Given this list of marker genes CRPPA, CTC1, MATR3, KCNJ13, NECAP1, PYCR2, MTHFR, ATP5F1A, DOLK, NIPA1, IKBKG, NOP56, ATP6V0A1, NAXD, ARSI, PTEN, HNRNPA2B1, LMNB1, ATP6AP2, CYP26C1, BBIP1, DLL4, CDON, MEOX1, AMFR, MAN2B1, PMS1, ERCC1, DOCK6, DPYD, NR2F1, MRPS34, BBS9, PRUNE1, TRAPPC4, TMEM222, FAR1, GSS, RNASEH2A, ZC4H2, TNR, DNAJC3, PDGFB, RLIM, NR4A2, TECPR2, FARS2, GTPBP2, GAS1, YRDC (NCBI Gene Id 79693), MOCS2, UBE4B (NCBI Gene Id 10277), PRPH, COL3A1, FUCA1, WWOX, UFC1, GALC, KCNA2, RPS6KA3, NDUFS1, HACE1, MYORG, DCX, MFSD2A, AARS1, ARL6IP1, SP110, EIF2AK1, GBA1, CWF19L1, KCNA1, SLC25A12, HPDL, RORA (RAR related orphan receptor A), DOCK8, BUB1B, GABRA5, GJC2, MKKS, APC, SPTLC1, DEGS1, TLR4, HLA-DRB1, PIGU, ENSG00000288330, FDX2, MSL3, MED13L, RUSC2, RAB3GAP1, GABRD, CEP85L, C2orf69, RNU4ATAC, TUBA1A, NSRP1, WARS2, SOX3, FOXH1, SEC31A, CACNA1G (calcium voltage-gated channel subunit alpha1 G), POLR3K, SMARCB1, ALG13, CHMP2B, RRM2B, WDR48, PI4KA, PEX3, ABCB7, CLP1, GCDH, TPK1, SELENOI, SPG21, HNRNPA1, CACNA1E, APC2, AFG3L2, SCYL2, STAR, SDHB, VPS50, VPS53, ERLIN1, MT-TS2, GRIN2D, SMARCAL1, MTR, SPR, TPP1, HEXB, CCR1, FKBP6, GABRG2, SOD1, ARHGAP31, NDE1, KMT2B (NCBI Gene Id 9757), TAF1, ADA2, GRN, NUBPL, TBX1, BOLA3, GTF2E2, TIMM8A, TMEM63A, DDC, MDH2, STAMBP, MEFV, FOXG1, PEX1, SMO, GABRA3, SLC1A2, CYB5R3, SLC19A3, AFF3 (ALF transcription elongation factor 3), SLC20A2, PHACTR1, FGF8, KDM5C, TUBB4B, RAB3GAP2, WDR73, NHLRC1, TRMT5, ATP2B3 (ATPase plasma membrane Ca2+ transporting 3), CASZ1, CEP290, MT-TW, NDUFS2, FIG4, CFH (NCBI Gene Id 3076), ANG, SPAST, LZTFL1, IL12A-AS1, NADK2, MPLKIP, FKRP, IRF2BPL, COQ4, DNM1, SLC38A3, MT-CO3, LIPT1, MT-ATP8, GTF2IRD1 (NCBI Gene Id 9569), RTN2 (reticulon 2), APOE, ZFR, PMPCB, SCAPER, TACO1, ITM2B, KCNC2, NSUN2, RNU7-1, OTUD6B, GM2A, DBT, ALG9, TMEM63C, UBE4A (NCBI Gene Id 9354), HSPD1, MT-TQ, TTC19, WDR45B, PEX19, MTOR, CAV1, NEUROD2, EXOSC9, PNPT1, TWNK, HSPG2, AGA, DARS1, TSC1, METTL5, SUCLA2, JAM3, PNPLA6, TBCD, NAA10, CLPB, HS6ST1, SLC12A6 (solute carrier family 12 member 6), PLAAT3, NDUFA8, ATXN8OS, TFG, UCHL1, AQP4, DNMT1, DPYS, RPE65, NUP62, SLC35A2, NPC1, GUCY1A1, KCNC3, BMPR1A, ATG5 (NCBI Gene Id 9474), HIKESHI, NTNG1, MFN2, KCNJ6, DLAT, PET100, PAX3, LAGE3, VWA3B, NPHP1, NMNAT1, TRMT10A (NCBI Gene Id 93587), ERCC8, KCNB1, PFN1, DDHD2, NDUFA6, ECHS1, SLC12A5, CCDC141, FKTN, PRORP (NCBI Gene Id 9692), PEX11B, GRIN2B, STN1, PEX6, LIMK1, TARDBP, NEU1, CDK19, ARPC5, SHQ1, TACR3, HRAS, DNASE1L3, GTF2IRD2, ANO10, UNC80, RPS20, SCN2A, PINK1, MT-CO1, ISCA2 (NCBI Gene Id 122961), TSEN2, LARGE1 (LARGE xylosyl- and glucuronyltransferase 1), LYST, AARS2, COQ8A, TUBGCP2, POMK, SPTBN2, MARS1, BCAT2 (branched chain amino acid transaminase 2), UBA5, DHDDS, PPFIBP1, MED23, COQ2 (coenzyme Q2, polyprenyltransferase), HINT1, PARS2, CTSF, HYCC1, PRSS12, PRKRA, BBS1, MRAP, MT-ND2, IREB2, ASPM, LMX1B, RNASEH2B, MRM2, CLCN3, ARF1, SQSTM1, CNKSR2, GLRB, MYO5A, C4A, EIF4H, KRAS, VPS37A, ZSWIM6, DLL1, TGFBR3, NDUFC2, CTSK, TH, BEAN1, MUTYH, POLG, ENTPD1, PON2, ERBB4, KCNJ18, TBC1D23, SLC39A14, POMT2, BRCA2, COA8, MED25, KIF1C, PGAP1, SOX2, SCN4A, FXN, ERCC5, BMP4, PON1, NDNF, CLIC2, DCC, THSD1, TYROBP, H4C5, ADSL, BBS12 (NCBI Gene Id 166379), CYP27A1, MT-CYB, FEZF1, BCAP31, NALCN, TPI1, RILPL1 (Rab interacting lysosomal protein like 1), GUCY2D, OPA1, SPEN, DCTN1, AKT1, SCN1A, TTR, HADHA, COG3, FBXO28, IFT172, PAFAH1B1, PCYT1A, RPGRIP1, NHLRC2, PSMC1, CYP7B1, RD3, TREX1, BCAS3, STAG2, ATAD3A, TUBG1, ODC1, POMT1, DDHD1, NDUFS4, RBMX, RNF13, FBLN1, SRPX2, TXNRD2, WDPCP, GFAP, AP4B1, GABBR2, GATAD2B, AP4M1, PTRHD1, AKT3, GLRX5, SCN1B, POLA1, ZFHX3, OPA3, KPNA3, NUP54, POLE, STIL, NAGA, VPS13C (NCBI Gene Id 57581), GJA1, DHCR24, SKI, POLR1A, HTRA2, MTTP, ISCA1, PRDM16, HSD17B4, ACP5 (NCBI Gene Id 54), LMBRD2, SIL1, AP1S2, GRIN1, MT-TI, IFNGR1, MOCS1, ERCC3, EXOSC8, IQCB1, FLRT1, UNC13A, COQ5, ABCD1, EEF1A2, MCOLN1, TREM2, LIMS2, KIF5C, PEX7, AASS, CNOT1, ATPAF2, PARK7, RPIA, THG1L, SVBP, ABHD12, SLC32A1, IL23R, PNP, ADAR, SUZ12, DARS2, SV2A (synaptic vesicle glycoprotein 2A), GRIA2, WDR62, INPP5K, GCH1, NDUFA4, ATN1, REEP2, SYNE1, TBP, CHP1, SLC33A1 (NCBI Gene Id 9197), PEX10, LYRM7, ATP6V1E1, ESAM, HLA-B, ETHE1, PACS2, REEP1, GPAA1, UGP2, TOE1, LIAS, SLC4A10, ATP6V0A2, LAMB1, GTF2H5, FLRT3, TGM6, IARS1, AFG2B, STXBP1, RNF113A, SERAC1, SDCCAG8, CFHR1, CAPN1, GFM1, RFT1, NUP133, CRIPTO, EARS2, REPS1, RNU4-2, COPB1, NTNG2, MAPK8IP3, PTS, ZIC2, RBPJ, SCLT1, SIK1, MC2R, ARSA, CFAP410, ABHD16A, BCOR, PROKR2, WDR4, GTF2I, OCLN (NCBI Gene Id 4950), SLC44A1, MFF, DTYMK, PTPN22, ATP5F1D, DLD, SLC18A2, CHMP1A, GLE1, DNAJC6, ATXN10, SARDH, CDC40, POLD1, ENG, TP53, USP8, GPT2, PCDH12, NOTCH2NLC, CAMK2A, TMEM270, MT-TK, GON7 (NCBI Gene Id 84520), MTPAP, MORC2, YIF1B, VRK1, ADAM22, TAF8, TAF4, SLC9A7, GAN, CDKL5, MT-TC, GDF6, CELF2, AP4E1, EDNRB, NFASC, ELN, NACC1, NPC2, ZNF668, BICD2, HID1, CRX, PLCH1 (NCBI Gene Id 23007), ASAH1, FAS, CAMSAP1, DAO, AAAS, TSEN15, DYNC1H1, RTTN, SYNGAP1, FLNA, DNAJC19, FTL, ATP7A, EIF2B1, BBS5, TNFRSF11A (NCBI Gene Id 8792), HLA-DPB1, IRAK1, NSD1, CNTNAP2, MRE11, SCYL1, GRIK2, HSD17B10, PPP2R2B, ARG1, ABCC8, GABRB2, BSCL2, TRIT1, KCNT1, PPOX, TMEM67, PIGP, FRRS1L, ATAD1, TAF2, NOTCH1, CRB1, SLC17A5, VAPB, SNCA, ITPR1, NEFL, DPM1, COASY, L1CAM, SZT2, HADHB, CACNA1B, FA2H, HMBS, EXOC2, ROGDI, ELOVL4, GBA2, HECTD4, NDUFA2, NDUFAF5 (NADH:ubiquinone oxidoreductase complex assembly factor 5), TARS1, MARS2, IFT27, FRMPD4, CAMLG, UBAC2, FZR1, WDR11, RDH12, RFC1, CYFIP2, POU4F1, COX15, POU3F3 (POU class 3 homeobox 3), ALG3, TGFBR2, SETX (senataxin), MCCC1, GOT2, PRDM13, ATL1, IFT74, L2HGDH, ANO1, PRPS1, EIF2B4, RNF170, ERAP1, ADARB1, PRKCZ, SLC25A46, CAMTA1, CACNA1A, COL4A1, SPTBN1, PDHX, SIX6 (NCBI Gene Id 4990), RAB18, IDUA, NDUFS3, GAMT, AGTPBP1, LETM1 (NCBI Gene Id 3954), CCDC88C, RAD50, SDHD, PRRT2, RAB27A, ALG11, ASPA, GAD1, EEF2, SAMHD1, ASNS, SAMD9, SPG11, DRG1, TUBB2B, SNX14, TTPA (alpha tocopherol transfer protein), MPZ, ADAT3, MTRFR, PEX16, DISP1, ELP2, UBAP1, SPOP, PRDM8, AIFM1, SPG7, GLI2, ATXN7, EPCAM, CASP2, B3GALT6, DDX3X, AUTS2, PLCB1, TPRKB, PODXL, CPSF3, OSGEP, NEFH, TRAPPC2L, MED27, UBQLN2, GABRA2, TUFM, POLR3GL, TAF15, GRM7, TSEN54, NUS1, EXTL3, RBM28, MED17, CRELD1, MKS1, LONP1, PDYN, PEX14, TSPOAP1, MICOS13, NUP107, ERCC4, FGF12, LRP12, SLC6A3 (NCBI Gene Id 6531), FBXO7, SUFU, WDR26, DNM1L, EXOC8, SIX3 (SIX homeobox 3), NNT, SNORD118, EXOSC3, LRP4, PSAP, HESX1, ADGRG1, ATP5MC3, MT-TF, PEX2, PAH, CARS2, PEX26, AMPD2, SACS, ANOS1, PRTN3, PAX6, KCNQ2, IL12A, PLCB4, JAM2, CLIP2, VCP, IFIH1, MT-ND6, CPT1C, STUB1, RERE, CCT5, MSH6, TPP2, SDHA, ATM (NCBI Gene Id 8068), SLC2A3, PPP1R15B, ALS2, NODAL, TMTC3, PSEN1, CCNF, PDGFRB, CACNA2D1, WDR45, ACER3, BDNF, PROK2, PANK2, POLR3A (NCBI Gene Id 11128), TSEN34, DKK1, EIF2S3, SEMA4A, MED12, ABCA12, CFHR3, HLA-DPA1, TBK1, SDHAF1, MLH1, ACTL6B, TRAF7, PQBP1, ATP1A2, VPS4A, GPRC5B, ACTB, MCCC2, ATP6V1A, CHCHD10, KARS1, NF2, PHGDH, PRF1, CEP19, XPC, RNASEH1, ATRX, ZFYVE26, DPH5, NEK1, COL4A2, NDUFV1, AP4S1, SEMA3A, KLRC4, ASCC3, DDB2, TMX2, IRF4, SOX4, EOGT, MT-ND3, CTNNB1, HCN1, SPATA7, GUF1, PCYT2, STAT4, EPM2A, CACNA1D, SCN5A, MT-ND4, ZNF335, ACADS, DMXL2, PRKN, SCN8A, SLC1A4, CHEK2, KY, ATP1A3, BCKDHB, TULP1, ADD3, RASA1, GLT8D1, WLS, PRNP, RFXANK, GRID2, NUP214, DYM, SATB1, COQ7, SLC25A15, ZEB2, COLGALT1, FOXP1, MTO1, GLB1, PIGN, BRAT1, SLC6A1, ACOX1, ACBD6, BAP1, PET117, PTPN23, AP1G1, SIGMAR1, IBA57, CYB5A, LRPPRC, CPT1A, BCS1L, IFT140, CRLF1, TCF20, LRAT, LIPT2, ARL6, SON, STX1A, ANK3, LIG3, TLR3, BBS10, VAMP1, SLC6A8, KCNAB2, YWHAG, VPS41, CASK, GBE1, CNTNAP1, CLCN4, BBS7, MT-TP, OPHN1, EIF2AK2, CYP2U1, NDUFAF4, SLC25A10, CSF1R, CHD7, CAMK2B, CHD2, TCEAL1, EXOSC5, TBL2, SMARCE1, LCA5, DYNC1I2, CLTC, ANKLE2, CTDP1, FTH1, ALDH18A1, PCLO, EBF3, MECP2, WASHC5, XPA, SATB2, TP53RK, PI4K2A, NAA60, TBCE, RAB11B, VPS11, BUD23, NOVA2, TTC8, ATXN1, ARNT2, SLC16A2, VPS13D, GPHN, SLC6A5, GDAP2, PPARGC1A, CA2, BBS2, HMGCL, EIF2B2, DUSP6, ERLIN2, MT-TL1, PEX5, MT-ND5, MT-ND1, DNAJC30, EIF4A2, NPPA, PMP2, TGIF1, DSTYK, TANGO2, TRAPPC12, GJB1, ATP5F1E, RNASEH2C, GEMIN4, CLN8, TIMM50, KIDINS220, TTBK2, PSAT1, AP5Z1, TUBB4A, ZBTB11, B4GALNT1 (NCBI Gene Id 550623), PPP3CA, GFM2, MLC1, ADPRS, TMEM106B, WARS1, LRRK2, ANGPTL6, PLA2G6, LSM11, NKX6-2, KATNB1, CTNNA2, SLITRK2, PIGT, ERCC6, KANK1, SOX10, AMACR, COG2, CNP (NCBI Gene Id 1267), MT-CO2, AIMP1, PNKP, IMPDH2, DHPS, THOC2, GMPPA, BCL11B, POMGNT1, C19orf12, VPS37D, MT-ATP6, NOTCH3, CLDN11, FGF17, ANXA11, CBS, CKAP2L, PHYH, SMPD1, CFAP418, MT-TH, LUZP1, GRIA3, SYNJ1, FUS (FUS RNA binding protein), NDUFV2, NT5C2, AGR2, ACAT1, DPM3, SLC5A6, CTCF, TEFM, INPP5E, OSTM1, KLC2, PIGQ, AP2M1, AHDC1, AFG2A, C9orf72, IMPDH1, FGF13, GNB1, H3-3A, RARS2, TCTN2, NDUFA13, GRIA4, TBC1D20 (TBC1 domain family member 20), IL10, CIT, MT-TE, ATXN2, SLC1A3, CACNA1C, CTLA4, SHH, SEPSECS, PDPN, SCN3A, DENND5A, INTS8, RANBP2, BBS4, SLC2A1, MMP23B, GNAQ, COX20, GNAO1, CACNA1S, PIGA, MT-TV, SPTAN1, RNF216, FRMD5, PTCH1, GLRA1, AIPL1, GSX2, DALRD3, SLC30A10, SPP1, B3GALNT2, AP3B2, UBTF (NCBI Gene Id 7343), TERT, SLC12A2, GIPC1, PMS2, METTL27, KCNA4, PPT1, KIF11, ATXN3, POLR3B (RNA polymerase III subunit B), PEX13, PNPLA8, ERCC2, SUOX, PIK3R5, TDP1, RNASET2, TSC2, RNF220, SUMF1, BTD, MTHFS, PEX12, SRD5A3, TGFB1, GLYCTK, PLAA, ELOVL1, PPIL1, HTRA1, PIK3CA, EML1, NAGS, MACF1, NEXMIF, SAMD9L, NAXE, ARX, WASHC4, B4GAT1, SNAPC4, TUBB3, NCF1, KIF1A, HPRT1, TRIM32, OPTN, IFT56, SETBP1, FDXR, EPRS1, HEPACAM, RHOBTB2, FCSK, RETREG1, UGDH, FGFR1, POLR1C, MECR, SLC25A22, COPB2, MTFMT, SPTSSA, IL17RD, SPRY4, GMPPB, MMUT, TBC1D24, SHMT2, UFM1, NTRK2, BAZ1B, MAPT, SPART (spartin), ATP13A2, TRAK1, AUH, SMC1A, COX8A, NF1, PON3, PLP1, HTT, RARS1, MRPS22, TRIM8, ATP5MK, SAT1, SLC13A5, ZNF592 (NCBI Gene Id 9640), CTSD, TTI1, KIF5A, GRM1, EZH2, WT1, TXN2 (thioredoxin 2), CARS1 (cysteinyl-tRNA synthetase 1), HLA-DQB1, LINGO1, TOR1A, NDUFS7, RFC2, TELO2, NFU1, RALGAPA1, MAG, GDF3, MINPP1, RAP1GDS1, PRICKLE1 (prickle planar cell polarity protein 1), MCEE, ALDH3A2, PMPCA (peptidase, mitochondrial processing subunit alpha), PMP22, KIF2A, MSH2, CNPY3, NARS2, OTX2, ARFGEF2, HUWE1, FBXL4, USP45, here is a description of the gene set: Human Gene Set: HP_UPPER_MOTOR_NEURON_DYSFUNCTION A functional anomaly of the upper motor neuron. The upper motor neurons are neurons of the primary motor cortex which project to the brainstem and spinal chord via the corticonuclear, corticobulbar and corticospinal (pyramidal) tracts. They are involved in control of voluntary movements. Dysfunction leads to weakness, impairment of fine motor movements, spasticity, hyperreflexia and abnormal pyramidal signs. Upper motor neuron dysfunction studied in species Homo sapiens